Given this list of marker genes Gltp, Cptp (ceramide-1-phosphate transfer protein), Pla2g4a, Gltpd2, Plekha8 (NCBI Gene Id 231999), here is a description of the gene set: Mouse Gene Set: GOMF_CERAMIDE_1_PHOSPHATE_BINDING Binding to ceramide 1-phosphate. species: Mus musculus